The following is a description of a gene set: Any process that modulates the frequency, rate, or extent of a response to biotic stimulus. species: Mus musculus Mouse Gene Set: GOBP_REGULATION_OF_RESPONSE_TO_BIOTIC_STIMULUS, and this is the list of marker genes: Ercc6, Nlrc3, Trim44, Cd84, Cep63, Apobec3, Stat5a, Rftn1, Plscr1, Sfpq, Casp4, Tigar, Srebf1, Cd96, Sfn, Cdc37, Usp27x, Il12b, Cgas, Naglu, Tspan6 (NCBI Gene Id 77150), Pvr, Ppp6c, Adam8, Tspan32, Zdhhc18, Il4i1, Ifi204, Unc13b, Tlr12, Ncf1, Trim21, Lrrc19 (leucine rich repeat containing 19), Rnf26, Tlr8 (toll-like receptor 8), Serpinb9g, Dcst1, Phb1, Traf3ip3, Xiap, Ncr3-ps, Gfer, Hexim1, Ccdc134, Grn, Mif, Gpr108, Ufl1, Otud4, Otulin, Ins2, Il27, Sarm1 (NCBI Gene Id 97709), Otop1, H2-T23, Elp6, Rsad2, Trim30c, Igf2, Raet1d, Ccl5, Lyn, Gbp5, Lrrfip2, Sh2d1b1, Cd300lf, Pparg, Prkd1, Ap1g1, Txk, Zc3hav1, Hsp90aa1, Elmod2, Med1, Nlrp1a (NLR family, pyrin domain containing 1A), Il15, Cd274, Ifi205, Rnf135, Irf2, S100a8, Slc22a13, Ereg, Ripk2, Ltf, Nr1d1, Tnip3, Ifi213, Atat1, Zcchc3, Ifi203, Clpb, Samhd1, Il23r, Dpp4, Clec7a, Ywhaz, Emilin2 (elastin microfibril interfacer 2), Trafd1, Peli3, Xrcc5, Map3k7, Ahr, Wdfy1, Lats2, Vsig4 (NCBI Gene Id 278180), Tyro3, Lep, Hcfc2, Mettl3, Inpp5d, Irf3, Atg5, Aim2, Znfx1, Il12a, Fgl2, Ptgs2os, Inava, Nlrp1b, Ly96, Nagk, Serpinb9e, Dhx9, Mavs, Klk7, Clec12b, Ptpn2 (NCBI Gene Id 19255), Oas1a (2'-5' oligoadenylate synthetase 1A), Sh2d1b2, Rps19, Serpinb9d (NCBI Gene Id 20726), Bmp6, Serpinb9c, Nfe2l2, Cd74, Traf3ip2, Drd2, Cx3cl1, Znrf4, Stmp1, Nlrc5, Fcna, Cd160, Slamf8, Gbp2b, Cd86, Pqbp1, S100a9, Sqstm1, Trim30b, Xrcc6, Trim30a, Epg5, Lyar, Nlrp4c, Ifi209, Oas1f, Zc3h12a, Rnf31, Cadm1, Reg3g, Prdx2, Ifi35, Ffar2, Fgr, Ticam2, Pja2, Irak3, Nploc4, Csnk1a1, Ivl, Polr3d, Oas1d, Ceacam1, Xcl1, Ywhae, Nlrc4, Prkdc, Syt11, Ptpn22, Prkaa1, Tnip1, Il21, Fpr-rs6, Klre1, Rnf115, Serping1, Klrc1, Tkfc, Pml, Arrb2, Ifna1, Letmd1, Mapkapk2, Tbk1, Gkn2, Cd300e, Tut4, Colec12, Rbm14, Trim41, Fcnb, Rps6ka3, Serpinb9h, Washc4, Ifi207, Zdhhc3, Lats1, Eif2ak4, Klri2, Fpr2, Ywhag, Cptp, Pdpk1, Aurkb, Cd300c2, Zdhhc5, Nono, Raet1e, Ddx60, Serpinb9b, Oas3, Mbl2, Kat5 (NCBI Gene Id 81601), Pla2g5, Nmi, Cd14, Card9, Trim31, Kcnk13, Clec4n, Syk (NCBI Gene Id 20963), Polr3g, Mndal (myeloid nuclear differentiation antigen like), Dhx58, Treml4, Tifa, Ppt1, Tlr1, Trim12c, Ifi214, Oasl1, Traf3ip1, Clnk, Zmpste24, Lbp (lipopolysaccharide binding protein), Casp1, Mapkbp1, Tnf, Usp38, Trim12a, Pik3r6, Bcl10, Gdi1, Oas1g, Riok3, Cd300a, Myo1f, Usp18, Apoe (apolipoprotein E), Ifi211, Tnfaip3, Gps2, Tax1bp1, Trim15, Sin3a, Tarbp2, Polr3c, Appl1, Btk, Aars2, Ifi203-ps, Spsb3, Erbin, Klk5, Tyrobp, Plcg2, Cfhr4, Creb3, Tlr9 (NCBI Gene Id 81897), Rnf216, Crk, Tlr5, Ifih1, Cd37, Clec4e, Nlrp4a (NLR family, pyrin domain containing 4A), Oas1c, Nlrp4e, Klrk1, Ptprs, Cd226, Klrb1f, Lamp2, Zdhhc4, Pim1 (proviral integration site 1), Sh2d1a, Brcc3dc, Slc15a3, Pycard, Wnt5a, Acod1, Casp6, Slc15a4, Nfkbiz, Lrsam1, Trib1, Pomc, Znrf1, Ipo5, Emilin1, Klrc2 (NCBI Gene Id 16642), Trim11, Ifi206, Cd36, Zbp1, Banf1, Rigi, Appl2, Optn, Parp14, Itch, Lag3, Irf7, Spn, Ddx3x, Mr1, Myd88 (NCBI Gene Id 17874), Mfhas1, Rab7b, Lsm14a, Eif2ak2, Ythdf2 (YTH N6-methyladenosine RNA binding protein 2), Sertad3, Eif4e2, Bpifb1, Pcbp2, Slc15a2, Ly86, Trim62 (NCBI Gene Id 67525), Ifnlr1, Ptpn6, Pum2, Ccr1, Gbp4, Nlrp6, Nlrp4f, Tril, Spi1, Trim25, Rela, Havcr2, Polr3b, Cfh, Pik3ap1, Tlr3, Stat5b, Irgm2, Fbxo38, Fam3a, Slc19a1, Irak2, Ogt, Alpk1, A2m, Trem3, Trim3, Rnf144a, Irgm1, Akirin2, Arf6, Dtx4, Dhx33, Parp9, Trim32, Lgr4, Klrb1a, Gbp3, Oas1e, Il18rap, Nlrp3, Stat1, App, Rnf170, Rasgrp1, Trim56, Mul1 (NCBI Gene Id 68350), N4bp1, Trim30d, Pdcd1, C1qbp, Mapk3, Cd300ld3, Casp8, Hmgb2, Klhl22, Il23a, Cyba (cytochrome b-245, alpha polypeptide), Tap1, Nectin4, Vav1, Ppp2r3c, Fbxl2, Nfkbil1, Serpinb9, S100a14, Tab1, Fpr-rs3, Pum1, Usp17le, Kcnj8, Cxcl1, Gimap3, Mmrn2, Sec14l1, Ticam1, Mapkapk3, Rasgrp4, Trex1, Zdhhc1, Cxcl5, Parp1 (poly (ADP-ribose) polymerase family, member 1), Dnaja3, Tasl, Ttll12, Rbm47, Nectin2, Tlr11, Arg2, Mill1, Mapk8, Calhm6, Tifab, Chuk, Rnf185, Selenok, Nlrp4b, Klrb1b, Ppp2ca, Gpatch3, Src (Rous sarcoma oncogene), Cactin, Dab2ip (disabled 2 interacting protein), Dusp10, Klrb1, Rtn4, Trim6, Zdhhc12, Peli1 (NCBI Gene Id 77964), Mmp12, Klrd1, Gata6, Flot1, Fosl1 (NCBI Gene Id 14283), Serpinb1a, Matr3, Ppl, Trim5, Smpdl3b, Irf1, Dtx3l, Gbp2, Tomm70a, Rnf26rt, Nek7 (NCBI Gene Id 98561), Cd55, Il4, Tgfb1, Lrrc14, Tlr7, Nr1h4, Clec2d, Ifng, Abhd17a (abhydrolase domain containing 17A), Ulbp1, Mefv (NCBI Gene Id 54483), Ubqln1, Traf3, Polr3f, Cd40lg, Il17f, Esr1, Il17a, Lamp1, Susd4, Isg15, Becn1, Atg12, Ins1, Mark4, Tlr2, Gfi1, Pten, Foxp1, Phb2, Gramd4, Rnf125, Klrc3, Usp29, Ankrd17, Serpinb9f, Ifi208, Hspd1, Igtp, Defb21, Ap3b1, Cav1, Hspa1b, Slamf6, Arg1, Slc46a2, Irf4, Lgals9, Grb2, F2rl1, Lrch4, Cnot7, Sirpa, Tlr6, Brcc3, Ube2k, D1Pas1, Cd24a, Smim30, Zdhhc11, Scimp, Gsdme, Tap2, Cd55b, Ptpn11, Klrb1c, Prkce, Nlrp10, Fadd, Ppm1b, Foxp3, Trem2 (triggering receptor expressed on myeloid cells 2), Pik3r1, Fpr-rs7, Oas1b, Gimap5, Nt5c2, Fpr-rs4, Sting1, Zdhhc9, Nfkbia, Rab34, Stat2, Nr1h3, Evpl, Dapk1, Oas1h, Rab11fip2, Il1b, H2-M3, Cd180, Traf6, Adar, Usp15, Trim38, Cd300c, Il12rb1, Hrg, Smpdl3a, Crtam, Unc93b1, Gbp7, Sirt2, Nod2, Tirap, Rnf34, Nod1, Lrp8, Pgc, Akt1, Muc4, Gm12250 (NCBI Gene Id 631323), Tlr13, Nop53, Cpt1a, Prkca, Ufd1, Htra1, Ecsit, Ninj1, Gm15441, Hmgb1 (NCBI Gene Id 15289), Gigyf2, Tmem126a, Hpx, Ddx39a, Klri1, Tlr4, P2rx7, Pspc1, Ilrun, Lyplal1, Ikbke, Hspa8, Irak1, Nlrx1, Usp50, Lacc1, Tnip2, Sash1, Ythdf3 (YTH N6-methyladenosine RNA binding protein 3)